Given this list of marker genes DUT, PWP1, PPIA, PSMA1, NAP1L1, ATP5PB, TBCB, CBFB, HMGN1, KHDRBS1, SNRPA, APEX1 (apurinic/apyrimidinic endodeoxyribonuclease 1), SRSF4, NDUFA12, SET, TPR, YWHAQ, IK, TCP1, BRD8, ACTG1, NCL, EEF2, POLG, SLC25A3, TRA2B, TCEA1, ZNHIT3, EIF4G2, VBP1, HNRNPD, HNRNPU, PRMT1, NASP, ATP5F1A, RPP30 (NCBI Gene Id 283012), HNRNPM, SRSF9, CSNK2B, CFL1, PSMA5, SNRPD3, PPP1R8, SUMO2, CCT7, CCT4, ILF2, NONO, ERH, EIF3F, NPM1, CAPZA1 (NCBI Gene Id 829), NACA, ATP5F1B, PPP1CC, NAE1, here is a description of the gene set: Neighborhood of PPP1CC protein phosphatase 1, catalytic subunit, gamma isoform in the GCM expression compendium Human Gene Set: GCM_PPP1CC Neighborhood of PPP1CC studied in species Homo sapiens